Given this list of marker genes FERMT2, MIR138-1, ADIG, ZBTB7B, SOD2, MIR27B, FNDC5, NAPEPLD, TRPM4, MAPK14, MIR103A1, CEBPA, MIR548D1, ZFP36, CREB1, PIM1, HES1, LEP, CDS1, CMKLR1, MIR21, VEGFA, WIF1, ZFP36L2, TFE3, HTR2A, TRPV4, ASXL1, STK4, MIR106A, MIR181A2, JAG1, CEBPB, ADIPOQ, PTGR3, SOX13, RORC, FTO, VSTM2A, CCDC85B (coiled-coil domain containing 85B), HDAC6, MEDAG, SIX1, XBP1, MIR17, NOCT, ATAT1, BMP2, WNT1, ANKRD26, LRP5, TRIB2, WWTR1 (NCBI Gene Id 25937), LMO3, HTR2C, DDIT3, DKKL1, ZFPM2, BMP7, SMAD3, SNAI2, ZFP36L1, SIRT2, LPL, GDF3, WNT10B, SYAP1, ALOX5, AAMDC, MMP11, TGFB1I1, MIR107, ZBTB16, ADIRF, TNF, SAV1, WNT3A, ASXL2, HNRNPU, SIRT6, LRP3, RORA, PTGS2, TPH1, MIR128-1, BBS12, MSX2, PPARG, CCN4, NR1D1, RREB1, YAP1, METRNL, KLF5, TRIO, SULT1E1, WNT5A, RARRES2, SLC7A10, ZC3H12A, TLCD3B, CCDC3, PPARD, FOXO1, MEX3C, TGFB1, FLCN, TAF8, TMEM64, INSIG1, ZBTB7C, STK3, TRIB3, GNB3, INS, ID2, ENPP1, FRZB, MIR448, DUSP10, RUNX1T1, MIR29B1, SORT1, E2F1, SIRT1, JDP2, FFAR4, CREBL2, WDFY2, SFRP2, GPER1, AXIN1, C1QL4, WNT5B, IL6, GATA2, PTPRQ, CARM1, BMAL1, AXIN2, DLK2, ZNF385A, ID4, AKT1, MIR483, GPS2, MIR27A, SFRP1, here is a description of the gene set: Any process that modulates the frequency, rate or extent of adipocyte differentiation. Human Gene Set: GOBP_REGULATION_OF_FAT_CELL_DIFFERENTIATION species: Homo sapiens